Given this list of marker genes SRPX2, PI4KA, GRIN2A, SPTAN1, ADGRG1, here is a description of the gene set: EEG with frontal focal spikes EEG with focal sharp transient waves of a duration less than 80 msec in the frontal region. Human Gene Set: HP_EEG_WITH_FRONTAL_FOCAL_SPIKES species: Homo sapiens